Given this list of marker genes Slc22a16, Slc22a1, Atp13a4, Slc22a3, Slc22a2, Atp13a2, Slc47a2, Atp13a3, Pou2f2, Atp13a5, Slc47a1, Slc18b1, here is a description of the gene set: Mouse Gene Set: GOMF_POLYAMINE_TRANSMEMBRANE_TRANSPORTER_ACTIVITY Enables the transfer of polyamines, organic compounds containing two or more amino groups, from one side of a membrane to the other. studied in species Mus musculus